The following is a description of a gene set: The process whose specific outcome is the progression of an epithelial cell over time, from its formation to the mature structure. An epithelial cell is a cell usually found in a two-dimensional sheet with a free surface. studied in species Mus musculus Mouse Gene Set: GOBP_EPITHELIAL_CELL_DEVELOPMENT, and this is the list of marker genes: Rac1, Ppp1r16b, Rock2, Adam7, Jmjd1c, Cdh1, Gdf11, Slc9a4, Hydin, Rock1, Tfap2c, F2rl1, Asxl1, E2f4, Notch2, Atf4, Rapgef2, Epas1, Akr1b1, Tgfb1, Id1, Mir203, Klf5, Sox18, Rdx, Cxcr4, Dact2, Adrm1, Hsd17b4, Sfn, Cldn5, Edn1, Trp63, Flnb, Lamb2, Src, Krt10, Mir503, Insm1, Clic4, Mir7-1, Smo, Psap, Tjp3, Gsdmc2, Clock, Ctnnb1, St14, Met, Pax6, Kdr, Epb41l5, Ubiad1, Add1, Cldn3, Cryaa, Akap9, Acta2, Bmp6, Dll1, Exph5, Fasn, Tfcp2l1, Tnmd, Tbc1d20, Frmd6, Col18a1, Arid4a, Cdsn, Nup210l, Msn, Rapgef1, Mir205, Ezr (ezrin), Onecut1, Cebpa, Marveld2, Zdhhc21, Fndc3a, Rarg, Map3k1, Rap2c, Atrx, Palld, Tigar, Scrib, Pkhd1, Sdc1, Ift74 (intraflagellar transport 74), Ntrk1, Fzd5, Arhgef26, Prox1, Fshr, Cgn, Adipoq, Smarca4, Tjp2, Abca12 (ATP-binding cassette, sub-family A member 12), Onecut2, Pdpk1, Vezf1, Prdm1, Bfsp1 (NCBI Gene Id 277454), Nkx3-2, Plec, Pard3, Rap1a, Afdn, Vcl, B4galt1, Plod3, Abcb1b, Icam1, Sox3, Bhlha15, Xbp1, Akap11, Six3, Gak, Rheb, Nphs1, Magi1, Cnmd, Tjp1, Vim, Tmigd1, Rab25, Tnf, Foxj1 (forkhead box J1), Rilpl1, Pde2a, Slc4a5, Agt, Gpat4, Amotl2 (angiomotin-like 2), Magi2, Fgfr2, Iqgap1, Notch4, Bmp5, Esr1, Fat1, Frs2, Map7, Ednra, Gata1 (GATA binding protein 1), Ikbkb (inhibitor of kappaB kinase beta), Kcnma1, Vegfa, Myd88, Shroom3, Stc1, Abcb1a, Sipa1l3, Ccm2, Mir874, Ccdc88c, Ptprs, Pde4d, Ednrb, Cdk6, Mir375, Vsig1, Hrh2, Esr2, Bmal1, Bad, Ihh, Hapln2, Bfsp2, Dicer1, Rapgef3, Dmd, Hoxb13, Hoxa13, Tmem79, Ar, Tlr9, Plcb1, Cdh5, Foxa1, Abi2, Dmrt1, Pecam1, Gpx1, Il6st (interleukin 6 signal transducer), Cdh2 (NCBI Gene Id 12558), Gja1, Wt1, Epha2, Rarb, Muc2, Gata2, Fer, Notch1, Cldn1, Nkx2-2, Hif1a, Tyms, Sox8, Krt2, Pgr, Rab13, Rfx3 (NCBI Gene Id 320548), Rara, Rnase10, Heg1, Arid4b, Rilpl2, Kdf1, Ift88, Mir214, Pof1b, Rap1b, C1galt1, Gpr4, Il1b, Fgfr3, Podxl, Adamtsl4, Kcne1, Bmp4, Tmod1, Wnt5a, Yipf6, Sidt2, Fem1b, Bcl11b, Nkx6-1 (NK6 homeobox 1), Tnfrsf1a, Mir541, Proc, Nr5a2, Ren1, Tfap2a, Flna, Spint2, Fosl2, Ampd2, Grhl2, S1pr3, Cdkn1a, Hoxa5, Foxc2, Pdgfb (platelet derived growth factor, B polypeptide), Robo4, S1pr2, Frzb, Yap1, Myadm, Luzp1, F11r, Ros1, Cftr, Hpse, Myo1e, Jag1, Crygb, Mir7-2, Nphs2, Sox9, Spdef, Foxp3, Il1a, Dnase1l2